The following is a description of a gene set: species: Homo sapiens Human Gene Set: GOMF_U6_SNRNA_BINDING Binding to a U6 small nuclear RNA (U6 snRNA)., and this is the list of marker genes: SART3, METTL16, RNU4-1, LSM7, EIF5A, LSM3, RBM22, LSM2, RNU4-2, PRPF8, LSM4, PRPF4, LARP7, LSM8, DDX39B, TUT1